Given this list of marker genes RPL38, 28S rRNA, RPL36A, RPL39L, RPS12, RPS26 (NCBI Gene Id 6231), RPS16, RPL7A, RPS29, RPL14, RPL24, RPS27A, RPL21 (ribosomal protein L21), RPL12, RPS15A, RPL39, RPS27, RPS19, UBA52, 5.8S rRNA, RPSA, RPL11, RPLP2, RPL3L (ribosomal protein L3 like), RPL26, RPL9, RPL32, RPS20, RPL36AL, RPS27L, RPL10L, RPS18, RPL28, RPS5, RPS4X, RPL18A, RPS13, RPL23A, RPL37, GSPT2, RPS9, RPL6, TRMT112, RPS25 (NCBI Gene Id 6230), 18S rRNA, RPL22 (ribosomal protein L22), RPL19, RPS4Y2, HEMK2, RPLP0, RPS3A, RPS23, RPS6, RPS8, RPL15, RPL31, RPS10, ETF1, RPL41 (ribosomal protein L41), FAU, RPS14, RPS28, RPL26L1, RPL22L1, RPL13A, RPL10A, RPL36, RPL17, APEH, RPL3, RPL4, RPS3, RPL10, RPL18, RPS15, RPL35A, RPL8, RPL27A, RPS21, RPS4Y1, RPS17, RPL23, RPL35, RPL13, RPL34, RPS7, RPL29, RPL5, RPS11, RPL37A, RPL30, RPL27, RPLP1, RPS24, RPL7 (NCBI Gene Id 6129), RPS2, GSPT1, 5S rRNA, here is a description of the gene set: part of: Translation species: Homo sapiens Reactome Pathway: Eukaryotic Translation Termination The arrival of any of the three stop codons (UAA, UAG and UGA) into the ribosomal A-site triggers the binding of a release factor (RF) to the ribosome and subsequent polypeptide chain release. In eukaryotes, the RF is composed of two proteins, eRF1 and eRF3. eRF1 is responsible for the hydrolysis of the peptidyl-tRNA, while eRF3 provides a GTP-dependent function. The ribosome releases the mRNA and dissociates into its two complex subunits, which can reassemble on another molecule to begin a new round of protein synthesis. It should be noted that at present, there is no factor identified in eukaryotes that would be the functional equivalent of the bacterial ribosome release (or recycling) factor, RRF, that catalyzes dissociation of the ribosome from the mRNA following release of the polypeptide